The following is a description of a gene set: from publication Shin DM, Shaffer DJ, Wang H, Roopenian DC, Morse HC 3rd (PMID 19010892) Aside from Myc-activating translocations characteristic of plasmacytomas (PCT), little is known about genetic factors and signaling pathways responsible for the development of spontaneous B-cell lineage lymphomas of mice. Here, we characterized the transcriptional profiles of PCT, centroblastic diffuse large B-cell lymphomas (CBL), and high-grade splenic marginal zone B-cell lymphoma (MZL++) using high-throughput quantitative reverse transcription-PCR. Expression profiles of CBL and MZL++ were strikingly similar and quite unlike that of PCT. Among the genes expressed at significantly higher levels by PCT were a number involved in NOTCH signaling, a finding supported by gene set enrichment analyses of microarray data. To investigate the importance of this pathway, NOTCH signaling was blocked in PCT cell lines by treatment with a gamma-secretase inhibitor (GSI) or transduction of a dominant-negative mutant of MAML1. These treatments resulted in reduced expression of NOTCH transcriptional targets in association with impaired proliferation and increased apoptosis. GSI treatment of transformed plasma cells in a primary PCT also induced apoptosis. These results integrate NOTCH activation with oncogenic signaling pathways downstream of translocated Myc in the pathogenesis of mouse PCT, two signaling pathways also implicated in development of human multiple myeloma and T-cell lymphoblastic lymphoma. Cluster 9 of genes distinguishing among different B lymphocyte neoplasms. Mouse Gene Set: SHIN_B_CELL_LYMPHOMA_CLUSTER_9 species: Mus musculus, and this is the list of marker genes: Cd79a, Tal1, Tlx1, Hmgb3, Mmp13, Spib, Cd40, Pax5, Cxcr5, Ikzf3, Bcl11a, Cd19 (NCBI Gene Id 12478), Wnt2, Rel, Hoxa4, S100a9, Gata1, Irf8, Nkx3-2